The following is a description of a gene set: Multiple myeloma is an incurable plasma cell malignancy for which existing animal models are limited. We have previously shown that the targeted expression of the transgenes c-Myc and Bcl-X(L) in murine plasma cells produces malignancy that displays features of human myeloma, such as localization of tumor cells to the bone marrow and lytic bone lesions. We have isolated and characterized in vitro cultures and adoptive transfers of tumors from Bcl-xl/Myc transgenic mice. Tumors have a plasmablastic morphology and variable expression of CD138, CD45, CD38, and CD19. Spectral karyotyping analysis of metaphase chromosomes from primary tumor cell cultures shows that the Bcl-xl/Myc tumors contain a variety of chromosomal abnormalities, including trisomies, translocations, and deletions. The most frequently aberrant chromosomes are 12 and 16. Three sites for recurring translocations were also identified on chromosomes 4D, 12F, and 16C. Gene expression profiling was used to identify differences in gene expression between tumor cells and normal plasma cells (NPC) and to cluster the tumors into two groups (tumor groups C and D), with distinct gene expression profiles. Four hundred and ninety-five genes were significantly different between both tumor groups and NPCs, whereas genes were uniquely different from NPCs in tumor group C and genes were uniquely different from NPCs in tumor group D. Similar to human myeloma, the cyclin D genes are differentially dysregulated in the mouse tumor groups. These data suggest the Bcl-xl/Myc tumors are similar to a subset of plasmablastic human myelomas and provide insight into the specific genes and pathways underlying the human disease. species: Mus musculus Genes up-regulated both in group C and D of tumors arising from overexpression of BCL2L1 and MYC in plasma cells. from publication Boylan KL, Gosse MA, Staggs SE, Janz S, Grindle S, Kansas GS, Van Ness BG (PMID 17483317) Mouse Gene Set: BOYLAN_MULTIPLE_MYELOMA_C_D_UP, and this is the list of marker genes: Ebf1, Taf1d, Supt16, Cfap298, Cecr2, Gabpb2, Snhg8, Tifa, Esrrb, Tmod1, Pkig, Ccdc85c, Atp5po, Iqgap1, Klc1, Ptprs, Pacc1, Ankrd37, Nap1l1 (NCBI Gene Id 53605), Sod2, Usp25, Farsb, Siva1, Gar1, Eps8, Gdpd3, Ddx19b, Bcl7a, Cep68, Fam43a, Srgap2, Lgr6 (NCBI Gene Id 329252), Prkacb, A530021J07Rik, Xylb, Zfp593, Norad, Rad51b, Niban3, Bcat1, Cdkn1a, 6820445E23Rik, Trim2, Brd8, Bcl2l1, Ncl, Tpm3, Otub2, Chchd6, Aff3, Zeb2, Cth, Acy1, Eprs1, Ppp1r36dn, Gpat3, Rad54l, Incenp, Sox4, Ppm1e, Rpl23, Ptk2, Pabpc1, Lingo3, Fus, Bach2, Klf9, Dynlt2a1, Amz1, Nolc1, Slc29a1, Gcn1 (NCBI Gene Id 231659), 1110038B12Rik, Rcor1, Egfl6, Sf3a3, Id3, Esco2, Tarbp1 (TAR RNA binding protein 1), Stxbp1, Bpnt1, Akap12, Idi1, Chml, Nt5dc2, Pinlyp, Pot1a, Mnd1, Gch1, Smpd4, Diras1, 2610005L07Rik, Sart3, Polh, Kif7, Utp25, Tra2a, Rbm38, Nudt21, Bcl11a (BCL11 transcription factor A), Tmem143, Hook3, Clasp2, Gid4, Agpat5, Dnajb4, Tfrc, Vpreb1a, Nat8l, Sbk1, Crocc, Pax5, Pdlim1, Bmal2, Sgms1, Fanca, Bambi, Ywhag, Zfas1, Rhoh, Irag2 (NCBI Gene Id 16970), Mark3, Srfbp1 (NCBI Gene Id 67222), Snrpf, Myl4, Gm11754, Pofut1, Sapcd1, Mthfd1, Diras2, Fubp1 (far upstream element (FUSE) binding protein 1), Mrps6, Slc16a1, Atad1, Edaradd, Cnn3, Dyrk2, Ap1s3, Cpsf2, Bag2, Scarb1, Serf1, Itsn1, Shmt1, Gsdme